Given this list of marker genes SNORD54, USP12, PSMB3, LIMD1-AS1, RNF138, ZNF839, WDR53, SACM1L, CTCF-DT, PKD1P6, AVEN, PBK, CCDC107, MPDZ, CSTPP1, STX16, HCG14, PRMT5-DT, POLG, KNL1, LARS2, LDHA, BCAR3, PARP2, ANGPTL6, MAP1LC3B, SMARCC2, POLR3E, RPS20, NDST2, FBXO31, AGBL5-AS1, FBXO45, PLEKHG2, H4C8, LTA4H, CERNA3, LINC02453, NDUFS7, PDS5B, STX16-NPEPL1, WIZ, CD274, VTRNA1-1, RNASE11, GTF3C3, RTTN, AGBL5, MIR4521, CTCF, PRMT5, POLG-DT, here is a description of the gene set: Genes containing one or more binding sites for (RBL1) in their promoter regions (TSS -1000,+100 bp) as identified by GTRD version 20.06 ChIP-seq harmonization. from publication Yevshin I, Sharipov R, Kolmykov S, Kondrakhin Y, Kolpakov F (PMID 30445619) studied in species Homo sapiens Human Gene Set: RBL1_TARGET_GENES